Given this list of marker genes HSF1, DNAJB1, CRYBA4, FKBP4, HSBP1, SERPINH1, DEDD2, HSPA1B, MRPL18, HSPA2, HSPA8, DNAJB6, HSPB1, HSBP2, CREBBP, COL4A6 (NCBI Gene Id 1288), PTGES3, HSP90AB1, HSPA1A, HSPH1, TNFRSF21, HSPA6, HSP90AA1, GML, UBB, HSPB2, EP300, HSPA1L, RLN1, here is a description of the gene set: species: Homo sapiens Reactome Pathway: Attenuation phase part of: HSF1-dependent transactivation Attenuation of the heat shock transcriptional response occurs during continuous exposure to intermediate heat shock conditions or upon recovery from stress. The attenuation phase of HSF1 cycle involves the transcriptional silencing of HSF1 bound to HSE, the release of HSF1 trimers from HSE and dissociation of HSF1 trimers to monomers. HSF1-driven heat stress associated transcription was shown to depend on inducible and reversible acetylation of HSF1 at Lys80, which negatively regulates DNA binding activity of HSF1 (Westerheide SD et al. 2009). In addition, the attenuation of HSF1 activation takes place when enough HSP70/HSP40 is produced to saturate exposed hydrophobic regions of proteins damaged as a result of heat exposure. The excess HSP70/HSP40 binds to HSF1 trimer, which leads to its dissociation from the promoter and conversion to the inactive monomeric form. Interaction of HSP70 with the transcriptional corepressor repressor element 1-silencing transcription factor corepressor (CoREST) assists in terminating heat-shock response (Gomez AV et al. 2008). HSF1 DNA-binding and transactivation activity were also inhibited upon interaction of HSF1-binding protein (HSBP1) with active trimeric HSF1(Satyal SH et al. 1998).